Given this list of marker genes MMP9, TGFBR2, PRKAA1, TRPC3, TNNI1, CASP9, TNF (tumor necrosis factor), NOS2, IL1A, SIGMAR1, SERPINE1, ITPR2, VDAC1, SLC25A5, IL1B, SMAD4, PLA2G4A, ITPR3, MMP2, PLAU, SNTB1 (syntrophin beta 1), IL6, FGB, SSPN, CACNG1, DAG1, CACNA2D1, TOMM20, ATP2A1, CACNA1S, MPO, ELANE, MCUB, TGFB1, CYBB, CASQ1, TRPC1, TRDN, AGTR1, ORAI1, SARAF, FKBP1A, CAPN3, SGCA, PLA2G2A, SCX, SPP1, GP2, TGFBR1, NFKB1, NOX4, CACNB2, HSPA9, IL10, CAMK2D, NFKBIA, GLI1, SMAD3, ITPR1, PRKAA2, PPIF, MCU, STIM1 (NCBI Gene Id 6786), CCN2, SMAD2, CACNA1F, TRPC6, DTNA, CACNB1, SLN, PRG3, RYR1, DMD, FGA, FGG, here is a description of the gene set: Human Gene Set: WP_AFFECTED_PATHWAYS_IN_DUCHENNE_MUSCULAR_DYSTROPHY species: Homo sapiens Affected pathways in Duchenne muscular dystrophy